The following is a description of a gene set: from publication Yevshin I, Sharipov R, Kolmykov S, Kondrakhin Y, Kolpakov F (PMID 30445619) studied in species Homo sapiens Genes containing one or more binding sites for (ZNF677) in their promoter regions (TSS -1000,+100 bp) as identified by GTRD version 20.06 ChIP-seq harmonization. Human Gene Set: ZNF677_TARGET_GENES, and this is the list of marker genes: CCSER2, OPN5, TMEM41A, CCT3, TESC-AS1, ADGRG4, HSD17B12 (hydroxysteroid 17-beta dehydrogenase 12), TMEM44, TBXA2R, DAP-DT, SETD7, TBCK, TM2D1, IGF2BP2-AS1, EFCAB5, VPS9D1, CFAP61, ARID1B, RNU6-800P, METTL21A (NCBI Gene Id 151194), PXK, RNU6-194P, CEP350, PER3, ZP2, LINC00997, SLC39A14, ZMYND11, SUZ12P1, TACC2, MIRLET7BHG, LINC01089, PLK1, NAIF1, FBXO9, ZNF337-AS1, ZNF343, BAZ2A, TAOK3, RHOF, ADRB1, LINC02432, IGFL2, TBC1D16, CEBPA-DT, EMG1 (EMG1 N1-specific pseudouridine methyltransferase), CLNS1A, TESC, WTIP, SHC3, INO80E, N4BP3, BPGM, CENPU, MMEL1, RUFY1, PHB2 (prohibitin 2), FTH1P23, NAPEPLD, IBA57-DT, NOTUM, RAB22A, SCN9A, PEF1-AS1, MLLT6, C2orf92, AGPAT2, ZKSCAN2-DT, DCAF4, MCRIP2, SAC3D1, KCNG2, EFCAB7, SH2D4A, CRELD2, FAM111A-DT, USP8, CICP17, RFWD3, FABP5P3, SLC25A25, ALG12, NSFL1C, IL17RD, CYMP, DDHD1, VPS4A, PIK3R4, GARS1, BRD7P4, MGRN1, ANKRD52, DRAP1, ATP7B, RAB11FIP5, ENSG00000237773, DYNC1LI2-DT, AFDN-DT, MYO18B-AS1 (NCBI Gene Id 105372963), IBA57, MED12L, ZNF394, KCTD15, GOLGA5, MINAR2, DPY19L2P2, ZNF514, SLC25A45, DAP, LRIG3-DT, UQCC1, MTRR, CEP55, FANCL, RNA5SP18, CSNK1G2-AS1, MATN2, HMGN2, TMPOP2, LRBA, DYNC1LI2, RBM6, INTS10, DIXDC1, PPP4R1L, TARS1, PPP1R15A, NUDT3, LINC01896, RNU6-626P, HMHB1 (histocompatibility minor HB-1), FIGNL1, AFDN, CSNK1G2, LRIG3 (NCBI Gene Id 121227), PEF1, BARX1-DT, PIAS4, TMPO, TNFRSF17, ZNF276, SMARCD2, ZNF362, TRIM67, GARS1-DT, STARD10, PAICS, SPATS2, CFTRP1 (CFTR pseudogene 1), NT5DC3 (5'-nucleotidase domain containing 3), WIPF2, POLR1A, SALL3, TRAV8-5, COMMD9, RNU6-1226P, AP2A2, ITPRIPL2, PIM3, ABHD12, RPL19P2, RGS12, QNG1, TBC1D12 (TBC1 domain family member 12), IBTK, CMPK1P2, CC2D2A, RBM17, GGA2, PPAT, ADGRL1, CEBPA, TRIM7, KMT2C, ZKSCAN2, RESF1, BARX1 (NCBI Gene Id 56033), SHCBP1, TARS1-DT, C11orf68, SP3, SEM1 (NCBI Gene Id 7979)